The following is a description of a gene set: Human Gene Set: GOBP_SUCCINYL_COA_METABOLIC_PROCESS The chemical reactions and pathways involving succinyl-CoA, a compound composed of the monovalent acyl group 3-carboxypropanoyl, derived from succinic acid by loss of one OH group, linked to coenzyme A. species: Homo sapiens, and this is the list of marker genes: NUDT8, SUCLG1, NUDT19, MMUT, ACOT4, OGDH, SUCLG2, SUCLA2, NUDT7, DLST (dihydrolipoamide S-succinyltransferase)